Given this list of marker genes CCL2, EP300, NFE2L2, MAFK, CREBBP, here is a description of the gene set: Human Gene Set: REACTOME_NFE2L2_REGULATING_INFLAMMATION_ASSOCIATED_GENES species: Homo sapiens NFE2L2 regulating inflammation associated genes